The following is a description of a gene set: The process whose specific outcome is the formation of dentin, the mineralized tissue that constitutes the major bulk of teeth. Dentin may be one of three types: primary dentin, secondary dentin, and tertiary dentin. Human Gene Set: GOBP_DENTINOGENESIS species: Homo sapiens, and this is the list of marker genes: SERPINE1, SMPD3, TCIRG1, SLC34A1, FAM20C, DSPP